The following is a description of a gene set: studied in species Mus musculus Reactome Pathway: SCF-beta-TrCP mediated degradation of Emi1 This event has been computationally inferred from an event that has been demonstrated in another species.<p>The inference is based on the homology mapping from PANTHER. Briefly, reactions for which all involved PhysicalEntities (in input, output and catalyst) have a mapped orthologue/paralogue (for complexes at least 75% of components must have a mapping) are inferred to the other species. electronically inferred by orthology from the curated human pathway part of: Regulation of APC/C activators between G1/S and early anaphase, and this is the list of marker genes: Rps27a, Fzr1, Cul1, Ubb